Given this list of marker genes Pax3, Sostdc1, Ccl2, Lrp6, Etv5, Msx2, Tbx3, Wnt5a, Tbx2, Stat5a, Epha2, Ddr1, Areg, Cav3, Elf3, Nrg3, Tfap2c, Esr1, Csf1, Scrib, Rxfp1, Gli2, Nr3c1, Wnt4, Vdr, Capn1, Ncoa3, Slc12a2, Gli3, Lrp5, Ar, Ntn1, Etv4, Stat6, Bsx, Phb2, Slit2, Cdkn2a (NCBI Gene Id 18560), Mst1, Pthlh, Bmp4, Tgfb1, Zfp157, Robo1, Rln1, Ccl11, Bax, Cav1, Btrc, Nfkb1, Igfbp5, Perp, Pml, Tgfbr2, Ptch1, Fgfr2, Med1, Kdm5b, Csmd1, Pgr (progesterone receptor), Src, Fgf10 (NCBI Gene Id 14165), here is a description of the gene set: species: Mus musculus The process in which anatomical structures of the mammary gland are generated and organized. Morphogenesis refers to the creation of shape. The mammary gland is a large compound sebaceous gland that in female mammals is modified to secrete milk. Mouse Gene Set: GOBP_MAMMARY_GLAND_MORPHOGENESIS